Given this list of marker genes Emp2, Flot1, Ilk, Col6a1, Pacsin2, Cav2, Iqgap1, Cav1 (caveolin 1, caveolae protein), Cav3, here is a description of the gene set: studied in species Mus musculus The aggregation, arrangement and bonding together of a set of components to form a plasma membrane raft. Mouse Gene Set: GOBP_PLASMA_MEMBRANE_RAFT_ASSEMBLY